The following is a description of a gene set: Reactome Pathway: Defective ALG2 causes CDG-1i Alpha 1,3/1,6 mannosyltransferase ALG2 (ALG2) is a bifunctional mannosyltransferase normally tranfers a mannose moiety to the lipid linked oligosaccharide (LLO aka N glycan precursor) which is required for subsequent N glycosylation of proteins. Defects in ALG2 can cause congenital disorder of glycosylation 1i (ALG2-CDG, previously known as CDG1i; MIM:607906), a multisystem disorder characterised by under glycosylated serum glycoproteins. CDG type 1 diseases result in a wide phenotypic spectrum, from poor neurological development, psychomotor retardation and dysmorphic features to hypotonia, coagulation abnormalities and immunodeficiency. Defect in ALG2 can also cause congenital myasthenic syndrome (ALG2-CMS), which is due to a defect in neuromuscular signal transmission. The most commonly affected muscles include proximal limb muscles. Mutations causing ALG2-CMS include p.V68G and p.72_75delinsSPR. part of: Diseases associated with N-glycosylation of proteins studied in species Homo sapiens, and this is the list of marker genes: ALG2